Given this list of marker genes SMPD2, DAB2IP, LINC02028, SVOPL, NAPA-AS1, LUZP1, ZNF761, EPS15, MIR4727, PPA2, KLHL22, CFAP44, ACACA, KCTD7, SLC16A1, ARRDC3, C2orf92, PDCD7, FAM114A1 (NCBI Gene Id 92689), ANKRD18DP, CRYZL1, SORL1, LHFPL2, CDK17 (cyclin dependent kinase 17), GEMIN7, CDKN2D, VPS13D, PIK3C2B, MSRA-DT, ASH1L, FHIP2A, KPTN, GNA11, SH3BP4, CBR3-AS1, EPB41L3, LIMS1, PARVA, RN7SL73P, MIR574, CTDP1-DT, KDM4C, DYNC1LI2, RNF121, MT-TH, SUPT16H, GAS1, SRSF12, SCMH1, TBL1XR1, LNCTSI, RTN4, AMT, PDXDC1, GLI2, SPSB2, VMA21, WNT7B, CTXND1, HM13-AS1, MT-TS2, HSDL1, CMAS, SLC38A2 (solute carrier family 38 member 2), EIF2AK3-DT, NHSL1-AS1, ELOVL2, KCTD14, ZNF813, ARHGDIB, LINC01387, IL1R1, CHMP4B, ISY1-RAB43, ACTR1B, MT-RNR1, MINK1, CAPS2, CRYGN, ZBTB34, PSTK, SIRT2, TRNP1, CDYL, MGAT5B, FBXL5, CSRNP1, HIPK1, FYN, RAB12 (RAB12, member RAS oncogene family), MET, SEMA3C, METTL1, LINC02609 (NCBI Gene Id 149351), INPP5F, LINC00957, RP9P, HDAC2, PDHB, C2orf49, GALNT7-DT, IKZF2, MIR6124, MT-TT, ENSG00000260830, CDH11, RASA4CP, CDRT4, TUBA1B (NCBI Gene Id 88851), MARK4, SP6, DGKZ, CPLANE1, CHKA, BECN1, SLC11A2, KCNB1, P3H4, TCF7L2, RANBP3, ITGAE, DNM1L, LNC-LBCS, MDK, KAT6A, SMURF2, GNAI1, KCTD18, RAI14, FAM13B, MAML3, PSD3, EFHD2-AS1, MYO1D, VRK3, WWC1, LACC1, AGK, ADAM22, CDH3-AS1, ANXA8L1, PINX1-DT, GATC, PLA2G6, ELOVL2-AS1, SHISAL2B, NEDD4L, CWC25, SLC38A2-AS1, MTRES1 (mitochondrial transcription rescue factor 1), KIF21A, PKMYT1, ISL1, ST6GAL2, FOXN3, RPL13P5, MT-ND6, DPYD, KHK, MT-ND4, CLCNKA, TRIAP1 (TP53 regulated inhibitor of apoptosis 1), WNT9B, ENSG00000236495, AMIGO1, ANKRD18B, ZNF426-DT, S100A2, SPG21, GLUL, IDH2, VPS51, AMD1, RAB7B, ACTN2, PEF1-AS1, DUSP1, MBOAT2, SKIL, ANKRD40, HSPB7, NKX2-3, NHSL1, MAGOHB, FBXO2, MT-RNR2, EIF4G1, CCDC124, ZNF22-AS1, EFHD2, HASPIN, LRRC23, ASXL3-DT, AIMP1, MT-TV (NCBI Gene Id 4577), ARID4A, SLC25A33, BCL7C, MAP2, PDE4D, AGK-DT, PCID2, CUL4A, P4HB, EXOSC9, CTTNBP2 (NCBI Gene Id 85447), SSU72, ATP6V1B2, TMEM245, ZNF614, HDAC2-AS2, HEY2, FRMD6, PPP2R2A, PPP1R3E, ADAMTS7P3, MAN1C1, PKP4, OLFML3, ST3GAL1, LINC01301, TPP2, SGO2, BICD1, FUCA2, ENHO, ZNF426, LINC00882, SEMA5A, MTA3, RPL18, ADAMTS18, RIC8B, MTCO3P12, VSIG10, ZNRF3-AS1, APLP2 (NCBI Gene Id 51680), FSTL3, MROH6, ETV5, SLC16A1-AS1, GPAM, MID1, MYADM, PINX1, GCFC2, MAPRE2, GLIPR1L2, C11orf68, TFAP4, ENTPD2, CCDC122, ID2, C2orf49-DT, RN7SKP114, DRAP1, MED15, ALDH1A2, SLC30A1, UBAP2, MYADM-AS1, HIPK1-AS1, TPM3P9, NPAS2-AS1, KCTD11, MT-TF, PAXBP1-AS1, LINC02709, S100A11, GPBAR1, NAXE, ANXA8 (NCBI Gene Id 653145), ANKRD10, RSRC1, MT-ND2, ANKDD1A, CHKA-DT, AHDC1, LEMD2, CBFA2T2, SCN8A, SLC35B1, NT5C2, CACYBP, CSK, NME7, SEPTIN9, PRIMPOL, FKBP10, NPL, CDS1, CMTR1, ZNF682, SIAH2, GNB4, LINC02171, OSBPL8 (NCBI Gene Id 57601), PPIL6, U2AF2, GABRA5, ARRDC3-AS1, LNCATV, SCNN1A, PIAS2 (NCBI Gene Id 9063), MNT, ZNF639, DESI2, ZNF664, ADGRV1, DNAJC27, ELOVL7, PKM, UBE2S, RAB2A, MIR4289, MST1P2, DUBR (DPPA2 upstream binding RNA), HEY2-AS1, LMBRD1, ERF, HSPB6, SSU72-AS1, COX19, MARVELD1, ENSG00000257545, POPDC2, SERTAD4-AS1, RAC2, PEF1, CFL2, ALDH3B1, BLZF1, TMEM17, NDUFA4, ZNF510, HOOK1, AK4, ZNF473, ATP5F1A, MRPS17, ECHDC1, CBX6, DHRS4L1, DIRC3, CDK18, RUNX1T1, FAM181B, TNNT2, MT-TE, SVEP1, CHEK1, LINC01271, IDH2-DT, DOK4, RORA-AS1, DACT3-AS1, ASB6, RALY, CTBP1, USP25, SYDE2, MGAT5, EEF1AKMT3, DYNC1LI2-DT, CRLF3, ID2-AS1, MFAP3L, PAQR8, PRMT3, MT-TM, CLDN10, CDC14B, MT-TI, PSKH2, ACTR3, SLC22A2, NCOA2, PROSER3, RNF187, RDX, PDGFC, SYBU, LINC01763, FBLN7, EDC3, DNAAF1, SMARCAD1, IRAG1-AS1, CROCCP2, ISY1, SSH1, GABRP, MITF, HDAC6, FER1L6-AS1, SUGT1P3, HRK, MRPL30P1, ETS2-AS1, TNFAIP3, AKR7A2, RERE, APBA2, ZNF341-AS1, MUC4, RBMS1, EPOR, FAM163B, KCNAB2, SGSM1, P2RY6, MIR4492, PSME3, SPRY4, ASXL3 (NCBI Gene Id 80816), LAMP1, CDYL-AS1, SLC12A8 (NCBI Gene Id 84561), HLCS, CTBP1-DT, DNAJC21 (DnaJ heat shock protein family (Hsp40) member C21), KDM2A, FAM222B, TTLL7, BICDL1, LTBR, ARHGEF11, AP1G1, EGLN2, TBRG4, TUBA1B-AS1, NOP56, SATB2-AS1, CTDP1, AMOTL1, ZNF527, CHD1-DT, TPTE2P5, FHAD1, COQ8B, FRMPD2, ACVR2A, CCDC92, XNDC1N, ICE2, STAT1, CDC16, SCMH1-DT, AGPAT3, ADGRA2, WNT3, SMARCAD1-DT, THY1, CDK12, NME9, CAPRIN2, TCAM1P (testicular cell adhesion molecule 1, pseudogene), DNAJC27-AS1, NR2F2-AS1, PXK, NXPE3, MFSD12, SLC66A1, PHF10, RESF1, EFHC1, PON2, SRF, SPHK2, PALM, BOD1, GEMIN8, RFLNA, ST6GALNAC6, CASP3, TBCK, SYNJ1, ULK1, ABCA4, FAM89A, ALPK2, DNAI1, RNF141, DIAPH1, ACER3, SUPT4H1, RAB31, NNT, SH2D7, CELSR1, PTCH1, here is a description of the gene set: Genes containing one or more binding sites for (HAND1) in their promoter regions (TSS -1000,+100 bp) as identified by GTRD version 20.06 ChIP-seq harmonization. Human Gene Set: HAND1_TARGET_GENES from publication Yevshin I, Sharipov R, Kolmykov S, Kondrakhin Y, Kolpakov F (PMID 30445619) species: Homo sapiens